Given this list of marker genes Pold2, Rfc5, Rfc4, Rpa3, Pole4, Pole2, Pole3, Pold3, Rfc3, Rpa2, Apex1, Pcna, Pole, Lig1, Rpa1, Polb, Fen1 (flap structure specific endonuclease 1), Pold4, Rfc1, Rfc2, Pold1, here is a description of the gene set: PCNA-Dependent Long Patch Base Excision Repair studied in species Mus musculus Mouse Gene Set: REACTOME_PCNA_DEPENDENT_LONG_PATCH_BASE_EXCISION_REPAIR